Given this list of marker genes Tuba3a, Zic3, Pou5f1, Prdm14, Piwil2, Crebbp, Nanos2, Tuba3b, Jmjd1c, Tfap2c, here is a description of the gene set: Any process by which an organism or tissue maintains a population of germ-line stem cells. Mouse Gene Set: GOBP_GERM_LINE_STEM_CELL_POPULATION_MAINTENANCE species: Mus musculus